Given this list of marker genes STAT3, GIPC1, SHC1, FRS2, RAP1A, RASGRF1, CCND1, RHOA, RIT2, NTF3, SQSTM1, PLCG1, BDNF, PIK3R1, RGS19, MAPK1, CRKL, DYNLT1, SHC2, EHD4, DNAJA3, ELMO1, CDC42, PRKCI, FRS3, GAB1, FAIM, MAP2K1, MATK, RAC1, RIT1, CRK, NGFR, NGF, GAB2, NTRK2, RHOG, GRB2, PTPN11, NTF4, NTRK3 (NCBI Gene Id 4916), PIK3CA, ABL1, SHC3, NRAS, SOS1, DNM1, PRKCZ, RAPGEF1, NTRK1, MAPK3, KRAS, RAP1B, SH2B1, MCF2L, DOCK1, TIAM1, NEDD4L, RASA1, HRAS, MAGED1, here is a description of the gene set: from publication Schaefer CF, Anthony K, Krupa S, Buchoff J, Day M, Hannay T, Buetow KH (PMID 18832364) Human Gene Set: PID_TRKR_PATHWAY species: Homo sapiens Neurotrophic factor-mediated Trk receptor signaling